The following is a description of a gene set: species: Homo sapiens Human Gene Set: HP_VERTEBRAL_FUSION A developmental defect leading to the union of two adjacent vertebrae. Vertebral fusion, and this is the list of marker genes: DCC, RAD51, BRPF1 (bromodomain and PHD finger containing 1), BMPER, ABCC6, MAFB, VANGL1, FLNB, FLNA, CHRND (NCBI Gene Id 1144), MYH3 (myosin heavy chain 3), FGD1, SF3B2, GPC3, MAP3K7 (NCBI Gene Id 6885), FN1, HES7, FUZ, NOTCH3 (notch receptor 3), LETM1, NSD2, SOX5, ASH1L, DLL3, SIX6, PLOD2, ENPP1, SMAD4, PUF60, KANSL1, TBX6 (T-box transcription factor 6), ACVR1, NADSYN1, CTBP1, DKK1, MEOX1, COL2A1, ANKRD11, CPLX1, PTCH1 (patched 1), HGD, ZIC3, IL1RN (interleukin 1 receptor antagonist), SALL4, FANCI, DNAL4, GDF3, PTCH2, MESP2, GDF6, FGFR2, CHN1, CHD4, SOX2, TBX5, GPC4, NOG, FKRP, AFF4, CHRNG, FGFRL1, ASXL2, WBP11, ROR2, RBM8A (NCBI Gene Id 9939), AEBP1, CHRNA1, MYO18B, SUFU, TMCO1, NTN1, CDH11, GDF5